Given this list of marker genes Slc29a1, Adgrf4, F630040K05Rik, B230354K17Rik, Gm25135, Tmem63b, Gm25008, Spats1, Hsp90ab1, Adgrf2, Runx2os1 (runt related transcription factor 2, opposite strand 1), Gm9104, Gm25783, Mymx, Adgrf1, Tdrd6, Enpp5, 1600014C23Rik, Opn5, Supt3, Runx2os3, Nfkbie, Gm5978, Tcte1, Tnfrsf21, Slc25a27, Rcan2, Ptchd4, Runx2os2, Mep1a, Cd2ap, Clic5, Cdc5l, Cyp39a1, Enpp4, Adgrf5, Gm35097, 4930564C03Rik, Mrpl14, Aars2, Runx2, Slc35b2, Capn11, Tmem151b, Ankrd66, Pla2g7, Gm4766, E130008D07Rik (RIKEN cDNA E130008D07 gene), 1700071M16Rik, here is a description of the gene set: studied in species Mus musculus Mouse Gene Set: chr17B3